Given this list of marker genes GNAO1, PRKACB, GNAI1, ATF2, CREB5, ADCY1, ADCY7, GNAI3, ADCY2, PRKACG, ADCY5, ADCY4, CREB3, ADCY3, CREB1, ADCY6, CREB3L4, GNAI2, ATF6B, PRKACA, ADCY8, CREB3L2, CREB3L3, ADCY9, ATF4, CREB3L1, here is a description of the gene set: Human Gene Set: KEGG_MEDICUS_PATHOGEN_HCMV_UL33_TO_GNAI_AC_PKA_SIGNALING_PATHWAY HCMV UL33 to GNAI-AC-PKA signaling pathway. Pathway ID: N00412. Pathway type: Pathogen. Pathway class: nt06167 Human cytomegalovirus (HCMV). Pathway Definition from KEGG: UL33 -> (GNAI,GNAO) -| ADCY -> cAMP -> PKA -> CREB species: Homo sapiens